The following is a description of a gene set: species: Homo sapiens Genes predicted to be targets of miRBase v22 microRNA hsa-miR-3174 in miRDB v6.0 with MirTarget v4 prediction scores > 80 (high confidence targets). from publication Chen Y, Wang X (PMID 31504780) Human Gene Set: MIR3174, and this is the list of marker genes: LRRC3, GIMAP2, SLC9A6, KANSL1, CXCL13, HMGB1, RPS29 (ribosomal protein S29), KAT6A, C1QTNF3, TIPRL, CHAC2, TAB3, KITLG, FOXN3, CHCHD3, KRBOX5, SH3TC2, SNRPA1, GNG11, FOXO1, CXCL9, ALCAM, ZNF41 (NCBI Gene Id 7592), WBP1L, ZNF616, ZFYVE21, DDX42, SLCO2A1, ZNF546, PMP22, ADAM15, NDUFA6, EPHA7, CNTF, NKAIN2, LILRA1, PIP4K2C, DAAM1 (NCBI Gene Id 23002), CHML, ZNF644, GPAM, KMT2C